Given this list of marker genes MPDU1, ASXL3, COG5, MKRN3, CLTCL1, CDKL5, PIGY, TCEAL1, PSAP, ZNF462 (zinc finger protein 462), SEPSECS, PSMC1, DALRD3, PDE10A (phosphodiesterase 10A), TRIO, KCNK9 (NCBI Gene Id 51305), UGDH, NALCN, RTL1, ALG12, TPM3, PIGT, TSEN15, RNF13, TP63, SPTLC1, NSUN2, CLCN6, PUF60, KRT14, TOR1A, TOM1, FAT4, CTCF, FBXO11, SPOP, FOXP2, AHDC1, PPP2R1A, FGF8, KRT5, COL4A6, AASS, TFG, KIAA0753, PGAP2, ASPA, TPM2, EHMT1, MYL1, EN1, DNM1, WAC, PIK3CD, ALS2, DLL1, MGAT2, MAP3K20, FBP2, DPM1, ITGA7, TBCK, HNRNPK, ABCD1, PNPT1, BLM, CDC42BPB, CAMLG, TSEN54, ALG2, RAPSN, PLP1, CARS2, SELENON, NAA10, LONP1, MOGS, GRIN1, PIGV, WDR26, FOXH1, CREBBP, SIGMAR1, GLI2, DISP1, NPAP1, ITCH, SON, NHLRC1, GPT2 (glutamic--pyruvic transaminase 2), PIGO, HERC2, PDHA1, PIGW, FDFT1, HACD1, SPG11, PACS1, SCN3A, PWRN1, PGAP3, ZNF699, SETBP1, SIM1, ADNP, SHH, OFD1, DTYMK, MECP2, CRELD1, SNRPN, SLC5A6, CLCNKA, MTRFR, C2CD3, TSEN2, ZIC2, CLCNKB, TGIF1, NODAL, KNSTRN, GALC, PLCH1, EPRS1, GNB2, EP300, SMC1A (NCBI Gene Id 8243), SNORD116-1, ACSF3, PIGU, RECQL4, PWAR1, MFF, LRPPRC, BRAF, AFG2A, SNORD115-1, SLC35A2, TSEN34, MT-TE, NONO, LMNA, KCNQ5, PTCD3, EDEM3, COL2A1, RALGAPA1, TRMU, MYO1H, CRIPTO, VPS50, GFM2, PSAT1, SPTBN4, PTPN23, MTM1, GRM7, KLHL40, CLN8, CDON, UNC80, POLR1A, MAGEL2, GAS1, FOXP3, COL4A5, GNS, DPM2, DYRK1A, STAG2, MYL2, AFF4, YY1, YARS1, SCN1A, SNF8, PIGL, HECW2, SYNE1, DEGS1, STIL, SCN4A, CLPB, KANSL1, COX8A, PTCH1, MEG3, LAMB2, DCHS1 (NCBI Gene Id 8642), IDH1, TRIP4, TXN2, PRPS1, FUS, SLC1A4, UBTF, FGFR1, COL7A1, NACC1, EPM2A, SIX3, ANAPC1, EIF4A2, SATB2, DNM1L, BSND, B3GALT6, ACTA1, GNPTAB, SRCAP, NRCAM, TRAPPC12, RNU4-2, DLK1, PGAP1, here is a description of the gene set: Human Gene Set: HP_TUBE_FEEDING Tube feeding Feeding problem necessitating food and nutrient delivery via a tube. species: Homo sapiens